The following is a description of a gene set: Mouse Gene Set: GOBP_ANATOMICAL_STRUCTURE_FORMATION_INVOLVED_IN_MORPHOGENESIS studied in species Mus musculus The developmental process pertaining to the initial formation of an anatomical structure from unspecified parts. This process begins with the specific processes that contribute to the appearance of the discrete structure and ends when the structural rudiment is recognizable. An anatomical structure is any biological entity that occupies space and is distinguished from its surroundings. Anatomical structures can be macroscopic such as a carpel, or microscopic such as an acrosome., and this is the list of marker genes: Smad2, Vps33a (VPS33A CORVET/HOPS core subunit), Epgn, Chad, Etv2, Pgk1, Ptch1, Nkx3-2, Ercc1, Slc4a2, Ar, Tgif1, Pdcd10, Trim71, Nf2, Tmprss12, Col4a2, Clasp1, Pthlh, Myog, Atf2, Spint2, Smarcd3, Adam9, Emilin1, Itgav, Adam17, Rora, Unc13d (unc-13 homolog D), Uspl1, Ins2, Actg1, Il17f, Dyrk1b, Emc10, Wars2 (NCBI Gene Id 99607), Jmjd8 (jumonji domain containing 8), Col4a3, Tmem182, Supt6, Hmgb1, Dusp5, Vegfd, Enah, Ptgis, Cldn5, Irx6, Fgfr1, Dll3, Cxcl17, Large1, Tsc1, Meox1, Fgfr2, Trp53, Zpbp, Shh, Ift172, Htatip2, Tead4, Kdm6a, Akap13, Nfe2l2, Nr4a3, Vash1, Akt3, Pax3, Pef1, Adm, Cav3, Fbxw7, Fbn2, Ackr3, Akt1, Wnt3a, Tnmd, Tubb1, Atp2b2, Plxnb2, Foxh1, Fzd6 (NCBI Gene Id 14368), Rab23 (RAB23, member RAS oncogene family), Tet1, Mpl, Ephb4, Nfatc1, Wdr1, Fbln5, Acvr1, Casp1, Ccl2, Ptgs2, Nfkb2, Synb, Hspg2, Tfap2a, Lepr, Arid1a, Tbr1, Agtr1b, Dvl2 (dishevelled segment polarity protein 2), Ywhaz, Chi3l1, Ptk2, Epb41l3, Ifitm1, Clic4, Sema6a, Actc1, Gata3, Tgfbr3, Scg2, Serpinf1, Parva, Rela, Tmod3, Pdgfb, Pnpla6, Cc2d2a, Ocstamp, Nfe2, Klf4, Rtn4, Cd34, Macf1, Myh9, Vdr, Ppara, Ace, Pofut2, Kif20b, Plxna1, Tnnt1, Bcl10, Mmrn1, Adgrb1, Hhex (NCBI Gene Id 15243), Pax6, Thbs1, Efnb2, Vangl2, Igfn1, Osr1, Apaf1 (NCBI Gene Id 76129), Scrib, Robo4, Mef2c, Ang2, E2f7, Esrrb, Leo1 (NCBI Gene Id 235497), Dspp, Pfn4, Bysl, Kdm6b, Notch2, Tal1, Cemip2, Wnt4, Nolc1, Angpt4, Bcl3, Pik3c2a, Hes1, Aplnr, Ang5, Rapgef3, Pank2, Hgf (hepatocyte growth factor), Gna13, Chn2, Gba1, Meox2, Luzp1, Axin1, Itga2b, Ptk7, Mtdh, Fmn1, Kif16b, Jam3, Spry1, Fhod3, Dchs1, Notch3, Armc5, Pou5f1, Ptpn11, Angptl3, Reck, Foxa2, Col11a1, Rgcc, Izumo1, Bmerb1, Tcof1, Itgb4, Zfp354c (zinc finger protein 354C), Junb, Fat3, Plg, Brca1, Rogdi, Aggf1 (NCBI Gene Id 66549), Cdx2, Nox1, Macroh2a1, Ptprj, Cib1, Dlx6, Syk, Tcf4, Pdpk1, Synj2bp, Cd93, Ada, Plk2, Tbx6, F3, Tnfrsf12a, Cd53, Nebl, Krit1, Foxd3 (forkhead box D3), Qki, Ecm1, Sox9, Minar1, E2f8, Yjefn3, Fut1, Ctnnb1, Lep, Tfap2c, Ep300, Cfl2 (NCBI Gene Id 12632), Tcf15 (NCBI Gene Id 21407), Pkm, Naxe, Enpep, Notch1 (notch 1), Itgb6, Whrn, Card10, Ppp2r3a, Cdk20, Uts2, Foxp2, Tnn, Prox1, Hoxb3, Wars1, Bmper, Tctn1, Arhgap24, Elk3, Dysf, Abl2, Klhl6, Xrcc2, Pkd1, Hipk1, Stard13, Flt4, Ccl8, T, Stk4, Ntrk1, Amotl2, Lgals3, Runx1, Flnc, Slc25a46, Nr2e1, Ppp3cb, Mesp2, Dkk1, Nrp1, Ugt8a, Cdon (cell adhesion molecule-related/down-regulated by oncogenes), Pafah1b1, Smpd3, Cntn1, Ift57, Sfrp2, Enam, Wls, Adamts1, Abca2 (ATP-binding cassette, sub-family A member 2), Map2k1, Gja1, Pik3r3, Rbpj, Neurog1, Gsk3b, Cxcl10, Wnk1, Tnfsf13b, Mmp15, Edar, Bmp10, Rspo3, Pten, Sdk1, Jcad, Ghrl, Pax2, Ccl24, Mfsd14a, Gnas, Fkbp1a, Smad4, Zic5, Kdm2a, Pfn1, Thy1, Tlx1, Amot, Btg1, Angptl4, Myh6, Axin2, Twist1, Sox2, Hhip, Cd160, Nr0b1, Micall1, Mfge8 (milk fat globule EGF and factor V/VIII domain containing), Nfatc4, Ncmap, Rdh13, Kif26b, Dscam, Gpr4, Gata6, Tmem201, Nppc, Tbpl1, Mapk3, Mecp2, Anxa2, Flvcr2, Matr3, Bmp2, Clic3, Neb, Ldb1 (NCBI Gene Id 16825), Hopx, Gdf3, Eng, Ift88, Mir27a, Plxna2, Fzd8, Pdcl2, Hey2, Agt, Myl2, Synpo2l, Vav3, Ets2, Epha2, Ccn1, Edn1, Tmed2, Tert, Pgf, Col5a2, Sash1, Ntf5, Vezf1, Gsc, Tmem100, Zic2, Wnt2, Pdpn, Plec, Fam209, Rbm46, Med1, Cdc42 (cell division cycle 42), Rras, Prdm14, Cfl1, Snai1, Mxi1, Mir126b, Mfng, Becn1, Cfh, Itgb1bp1, Itgb3, Sh2b3, Plxnd1, Cdc73, Gnpat, Wt1, AU040320, Relt (RELT tumor necrosis factor receptor), Foxn4, Tfap2b, Slit2, Neo1, Rhob, Ahr, Prl7d1, Thbs3, Gm28729 (predicted gene 28729), Ccm2, Pou2f1, Mybpc3, Cep290, Shb, Pparg, Ckap5, Slc44a4, Stra6, Nop2, Ilk, Hsbp1, Ddah1, Ccdc136, Hipk2, Ccdc42, Tgfb1, Atp7a, Aldh1a1, Mios, Smarca1, Prom1, Ppp1r15a, Herc1, Vegfb, Actn2, Eqtn, Eif2ak3, Camp, Nkx3-1, Rara, Lhx2, Opa1, Aldh1a2, Rps7, Nfix, Csrp1, Bmpr1a, Acta1, Tafa5, Bmpr2, Srpk2, Glul, Ctr9, Atxn2, Izumo3, Actl7a, Mypn, Rc3h1, Hif1a, Syna, Efna1, Ccdc134, Tbx5, Adtrp (androgen dependent TFPI regulating protein), Minar2 (NCBI Gene Id 225583), Tnfsf12, Hes5, Brd3, C3ar1, Srpx2 (sushi-repeat-containing protein, X-linked 2), Sec24b, Gpc1, Thbs4, Vasp, Ift52, Pik3ca, Tie1, Plau, Hspb1, Acvr2b, Smoc2, Pdgfra (NCBI Gene Id 231312), Ptn, Spaca1, Cftr, Il4, Foxj1, Pecam1, Ptk2b, Tnnt3, Smo, Ercc2, Sec23ip, Egln1, Hmox1, Mixl1, Gpr15, Ang6, Nectin2, Robo2, Ret, Map3k3, Wdr83, Gli2, Lmod2, Ago2, Col3a1, Ccnb1ip1, Aqp1, Tmod4, Smarca4, Chrd, Hoxd11, Agfg1, Lfng, Gabpa, Sema3e, Grhl2, Six4, Sema3c, Ngp, Smad5, Cdh1, Pik3r6, Mcam, Folr1, Mmp20 (NCBI Gene Id 30800), Or10j5, Garin3, Pcdha9, Socs7, Ccbe1, Nbeal2, Hoxa1, Cxcl9, Skor2, Pla2g3, Cnot3, Lhx1, Cxcr2, Specc1l, Ppp1r16b, C1galt1, Mthfd1l, Foxj2, Calcrl, Fzd7, Myh10, Kdr, Wnt5a, Ptpn18, Nfib, Kdm2b, Bcl6, Erap1, Tbxa2r, Polr1b, Dkk4, Foxa1, Mfn2, Ereg (NCBI Gene Id 269673), Myoz2, Wasf2, Phldb2, Otulin, Gng5, Casq2, Psen1, Exoc4, Itgb1, Atm, Hoxa3, Rnh1, Klf2, Gdf7, Fgf2, Tmod2, Hand1, Lrp2, Grn, Mir24-1, Itgb8, Cavin4, Cspg4, Kctd10, Fgfbp1, St14, Ecsit, Tnfsf14, Smad1, Prl2c2, Klk5, Tifab, Cd9, Cecr2, Pax1, Bsg, Atp8a2, Camk1, Hdac5, Nfatc3, Myom1, Flot1, Hdac9, Wnt6, Mef2a, Zeb2, Acrbp, Tek, Ndp, Sall1, Sox17, Bmp5, Bmp7, Csrp2, Ripor2, Pknox1, Itga8, Thbs2, Pax8, Casq1, Wnt11, Rnf213 (ring finger protein 213), Sdc4, Spry2, Alox5, Ahdc1, Glmn, Scx, Lemd2, Gdf2, Amtn, Tlx2, Nrarp, Garin1b, Mmp8, Rtl1, Ascl5, Cdx1, Nf1, Scgb3a1, Ncl, Ninj1, Brpf1, Gata2 (NCBI Gene Id 14461), Mag, Rxra, Fgfr4, Dll1, Ankrd23, Nos3, Dicer1 (NCBI Gene Id 68462), Lrp8, Lhx5, Jmjd6, Capn2, S100a1, Dlc1, Neurl2, Npr3, Csrp3, Hk2, Htt, Mks1, Mymk, Apln, Rarg (retinoic acid receptor, gamma), Nanog, Rs1, Cacna1a, Epas1 (endothelial PAS domain protein 1), Tspan18, Fgf18 (NCBI Gene Id 319384), Rrp7a, Ophn1, Stk3, Angptl6, Ssbp3, Sox11, Dab2, Ephb2, Hand2, Shank3, Isl1, Ptpn6, Traf6 (TNF receptor-associated factor 6), Fsip1, Irx3, Thsd7a, Phldb1, Jak1, Mir23a, Sars1, Wnt1, Mybph, Hes7, Zp3, Xbp1, Map3k7, Hectd1, Zfpm1, Flt1, Rab1a, Myoz1, Deaf1, Ccl12, Ccn3 (NCBI Gene Id 18133), Il1b, Hesx1, Adamts5, Sox18, Cd59a, Klhl12, Txnrd1, Sulf1, Rasip1, Txnrd3, Spink2, Mfap2, Tead2, Gata1, Abi1, Adrb2, Cybb, Vhl, Ramp2, Crhr2, Egfl7 (NCBI Gene Id 353156), Egr3, Mkx, Tmod1, Mir216a, Faim2, Hspb6, Myh11, Col4a1, Cd47, Mtmr2, Ptpn20, Prkar1a, Lias, Dusp2, Ldb3, Irx2, Pdcd6, Nodal, Loxl2, Fgf8, Cdk5r1, Bmp4, Pln, Ptpn14, Il18, Ago1, Emilin2, Gadd45a, Pikfyve, Cx3cr1, Rock2, Tnfsf13, Adgrg6, Casp8, Arhgap35, Cd109, Gata4, Cd81 (CD81 antigen), Pals1, Wnt7b, Hif3a, Flna, Fgf1, Nkx2-5, B4galt1, Tbx20, Ski, Apela, Csf1r, Foxo4, Apoh, Tgfbi, Bcam, Mtpn (myotrophin), Il12b, Pdgfrb, Cyp1b1, Lamb3, Dll4, Pacsin2, Phox2a, Epo, Hspa12b, Nrxn3, Tbx4, Fasl, Col18a1, Trp63, C3, Sirt1, Pgm5, Fhl2, Vav2, Grhl3, Hnf1b, Ovol2, Pik3r2, Cnnm4, Rpl7l1, Gata5, Perp, Cd40, Klk4, Mmrn2, Hoxa7, Rgma, Dlx5, Sdk2 (sidekick cell adhesion molecule 2), Plcg1, Rock1, Pofut1, Ccn6, Dock2, Rdh10, Mapk7, Mymx, Notch4, H2-DMa, Esm1, Mthfr, Serpine1, Lif, Emp2, Zic3, Slc9a8, Cxcr4, Eda, Nckap1 (NCK-associated protein 1), Adgrg1, S2bpcox16, Cdk5, Zc3h12a, Prok1, Abcc8, Ext1, Actl6a, Wnt7a, Tmem215, Sema4a, Adipor2, Angpt1, Psap, Mir27b, Reln, Wdr72, Nrcam, Itga2, Msx2, Clec14a, Ttn, Cav1, Mmp19, Lrg1 (leucine-rich alpha-2-glycoprotein 1), Zpbp2, Sox7, Aldh1a3, Npr2, Mapk14, Robo1, Ctsh, Gpx1, Sox8, Pllp (plasma membrane proteolipid), Il10, Mobp, Slc24a4, Mapk1, Fgf9, Hoxa5, Tlr2, Ubp1, Map2k2, Cysltr2, Ang4 (NCBI Gene Id 328486), Rala, Ceacam1, Sptbn1, Itgb2 (integrin beta 2), Amelx, Vstm4, Tenm4, Nkx2-1, Gatad2a, Tlr3, Col6a1, Atoh8, Furin, Prkd2, Atp2b4, Taf10, Arl6, Tpm1, Ppargc1b, Tgfb2, Tcf21, Tjp1, Garin1a, Eomes (NCBI Gene Id 97512), Itga3, Eya1, Prkaca, Med12, Ephb3, Tnf, Adamts15 (ADAM metallopeptidase with thrombospondin type 1 motif 15), Nfasc, Crb2, Pmp22, Coq7, Kbtbd8, Ramp1, Pik3cd, Acvrl1, Hpse, Il36g, Palb2, Sf3b1, Elf5, Tbx2, Pkn1, Sf3b6, Fn1, Hdac1, Rbp4, Heyl, Amotl1, C5ar1, Vps4b, Yap1, Cacna1s, Nrp2, Cysltr1, Tbx19, Alx1, Meis3, Skil, Ift122, Dcn, Megf11, Tbx18, Phactr4, Hrg, Cbln1, Flii, Stim1, Ipmk, Adra2b (NCBI Gene Id 11552), Slc31a1, Ccdc38, Gtf2i, Nus1, Rbm15, Adgrb2, Cited2, Ihh, Hoxc11, Fyn, Tnrc6c, Vegfc, Ccl11, Sbno2, Cflar, Aimp1, Sema5a, Dock1, Tgfbr1, Meis1, Mir23b (NCBI Gene Id 387217), Add1, Pnldc1, Hey1, Rhoa, Il4ra, Clec1b, Gja5, Mydgf, Mir217, Olfm1, Shc1, Dcaf17, Apold1, Flt3l, Actn1, Snai2, Zfp219, Msx1, Nrap (NCBI Gene Id 18175), Dab2ip (NCBI Gene Id 98996), Pak4, Pdgfa, Dag1, Spem3, Gpld1, Foxb1, Edn2, Mesp1, Rtf1, Wdr74, Pxn, Pdcl3, Ext2, Pxdn (peroxidasin), Plekho1, Rhoj, Tgfa, Spint1, Mia3, Slc39a12, Zfpm2, Enpp1, Adgra2, Vash2, Efna3, Hs2st1, Hmga2, Tpm4, Zfp385a, Epb41l5, Adgrb3, Foxf1, Stat3, Ptgfrn, Tbc1d20, Ccr2, Calb1, Myf6, Dusp4, Cnmd, Cd36, Dock5, Dmp1, T2, Ctnnd1, Col12a1, Angpt2, Anxa1, Cylc1, Naa15, Fig4 (NCBI Gene Id 103199), Rbm20, Tmf1, Ghsr, H2-M3, Hoxa11 (homeobox A11), Kndc1, Grem1, Uts2r, Ccn2, Nfatc2, Ehd1, Lama3, Pramel7, Kdm4c, Pcdh8, Myf5, Csf3r, Slc12a2, Ttc21b, Gbx2, Sdccag8, Psg22, Map2k5, Srf, Id1, Plcd3, Nectin1, Gcm1, Pml, Foxo1, Nog, Six2, E2f2, Casp3, Tcap, Cx3cl1 (NCBI Gene Id 58173), Optc, Kat2a, Il12a, Prkd1, Cdh5, Prkca, Fzd3, Mir329, Ripply2, Mybpc2, Ulk1, Gpi1, Tnfaip2, Odaph, Myl9, Fam20c, Cela1, Hbegf, Tnnt2, Adam12, Rfx2, Epha1, Hgs, Igf2, Il1a, Jun, Tanc1, Prkacb, Mdk (NCBI Gene Id 17242), Slc40a1, Cxcr3, Ehd2, Ror2, Col8a1, Wnt3, Nrxn1, Fkbpl, Gdnf, Spred1, Arhgap22, Mmp14, Tbx3, Mpig6b, Hnf1a, Poglut1, Tgfb3, Mthfd1, Sp100, Sufu, Plcd1, Pik3cg, Mmp9 (matrix metallopeptidase 9), Mybpc1, Stil, Tm4sf1, Frs2, Pbrm1, Ripply1, Atp5f1b, Nr5a2, Gli3, Prickle1, Ccr3, Spem1, Tcta, Sp3, Unc5b, Shroom3, Mylk3, Ptprb, Sall4, Fgf6, Ism1, Fgf3, Sphk1, Hdac7, Grid2, Vegfa, Prkdc, Cluap1, Tnfrsf13c, Sppl2c, Prx, Itgax, Vtn, Prcp, Foxd1, Otx2, Sec1, Mafb, Agtpbp1, Trem2, Col1a1, Cnot2, Xirp1, Ulk4, Bcl2l11 (BCL2 like 11), Psen2, Mir24-2, Fap, Sox30, Wnt9b, Epn2, Fgf10, Fuz (fuzzy planar cell polarity protein), Wnt2b, Hc, Cd44, Creb3l1, Nphs1, Podxl, Dmrt2, Irx1, Lmo4, Nup50, Tnfrsf1a, Ccng1, Smad3, Vps13b, Ngfr, Sh3pxd2a, Sirt6, Adam15, Lats2, Emcn, Agtr1a, Lats1, Lmod1, Cma1, Slc1a1, Hoxb13, Dsg2, Tgfbr2, Tyrobp, Dusp1, Pf4, Cul3, Setd2, Myod1, S1pr1, Hyal1, Anpep, Fzd4, Stab1, Cthrc1, Adam8, Cyp27b1, Bbs4, Sp1, Myom3, Pim1, Actl9, Pde3b, Cntnap1, Col5a1, Paf1, Lemd3, Celsr1, Adamts9, Itgb2l, Lmod3, Ntn3, Col2a1, Atp8b1, Cnot1, Ednra, Msgn1 (NCBI Gene Id 56184), Ccl5, Tgm2 (transglutaminase 2, C polypeptide), Jup, Egr2 (NCBI Gene Id 13654), Wnt10b, Nrg3, Tnfaip3 (tumor necrosis factor, alpha-induced protein 3), Ppp3r1, Prkx, Epn1, Nle1, Fjx1, Ptprm, Cdh13, Dcx, Fam20a (FAM20A, golgi associated secretory pathway pseudokinase), Grb2, Tbx1, Plxna3, Tulp3 (NCBI Gene Id 69552), Sfrp1, Ehd4, Cend1, Cylc2, Capn3, Ephb1, Twsg1, Ets1, Sema4c, Agfg2, Stat1, Hs6st1, Tspan12, Lef1, Pitx2, Lrp6, Gdf15, Prkcb, Prok2, Mmp2, Abl1, Adm2, Cdk5r2, Fmnl3, Mir216b, Clasp2, Mib1, Nr4a1, Krt19, Ndnf, Tsc2, Tcirg1, Klhl41, Pik3cb, Cxcl12, Foxc2, Gab1, Klf5, Myom2, Sparc, Ecscr, Ptf1a, Six1, Ttll1, Itga5, Inhba, Foxc1 (forkhead box C1), Brd2, Nras, Col8a2, Poc1b, Ang, Hdac2, Dcstamp, Anxa3, Hoxb1, Adprhl1, Bcas3, Tppp, Fzd5, Mboat7, Cobl, Krt8, 2210016L21Rik (RIKEN cDNA 2210016L21 gene), Egf, Crb1